The following is a description of a gene set: from publication Costello P, Nicolas R, Willoughby J, Wasylyk B, Nordheim A, Treisman R (PMID 20554967) Removal of the transcription factor SAP1a member of the Ternary Complex Factor (TCF) group of transcription factors which in conjunction with Serum Response Factor (SRF) has been shown to have a profound effect on positive selection in the thymus. When another TCF Elk1 is knocked out in mice there is no effect on positive selection unless it is on a Sap1a KO background where the phenotype is very severe. We have stimulated isolated double positive T cells (DPs) with anti-CD3 to mimic positive selection and compared basal and stimulated transcription across the four genotypes to discover the downstream targets of Sap1a involved in positive selection. Genes down-regulated in double positive thymocytes with ELK1 and ELK4 knockout: untreated versus stimulated by anti-CD3. Human Gene Set: GSE21546_UNSTIM_VS_ANTI_CD3_STIM_SAP1A_KO_AND_ELK1_KO_DP_THYMOCYTES_DN studied in species Homo sapiens, and this is the list of marker genes: PEX11G, SLC43A3, MARCHF10, FRG2EP, AKAP7, ACSL6, RNF180, PCDHA10, TLR9, OR1A2, LINC01123, TTTY13, ADRA2C, PSEN2, ASPRV1 (aspartic peptidase retroviral like 1), TSPAN16, PCDHA6, HHIP-AS1, GAS6-DT, GPATCH11, SLC5A7, H2AP, OOEP (NCBI Gene Id 648473), LINC00319, DNAJB8-AS1, LINC00269, CNNM4, CLVS2, SLC24A4, BPIFB6, ST8SIA1, CABS1, ZFP64, UBE2Q2P13, SLC8A1-AS1, SLPI, MYL2, GK2, ENSG00000267882, UBE4B, NPAS2, CAVIN2, HLA-DOA, TSEN54, PTH, WNT5B, SPAG11A, KCP, LINC02871, DKKL1, HRH3, RBM46, ZNF771, IGLV1-44, CSN2, FNDC9, CATSPERZ, PADI4, C1QA, SOCS4, SLC22A16, FGF6, CITED1, PNPLA7, LGR6, CRYAA, OR1E1, FRMPD4, ZNF507, TRMT44, CTC1, GHSR (growth hormone secretagogue receptor), TSPAN9 (NCBI Gene Id 83441), UMODL1, SFTPC, HTR1A, EQTN, KRTDAP, KRTAP11-1, LINC00921, GNG13, UGT2B28, APOA1, CYP3A43, PAMR1, S1PR1, MGC27382, TEX26, SEMA6B, CCDC172, PIK3C2B (NCBI Gene Id 5287), MTUS2-AS1 (NCBI Gene Id 731614), OR2M4, CTNNA3, OR10J1, SSTR1, DNAJB9, CRMA, PRR34, PSORS1C3, SPATA31H1, CYP19A1, ARB2A, CIMAP1C, FMO9P, FAM223A, IL2RG, CD4, CTDSP1, LINC00951, DELEC1, JPH1, SPIB, ITGB7, GOLGA8IP, SLC9A9, NTSR2, CBX7, DCAF13, CRACR2B, PRSS47P, IGSF21, CD3D, PSG1, NR2F2-AS1, LINC02487, TSSK3, LRFN2 (NCBI Gene Id 57497), DHRS13, CALCR, NANP, C1RL, SCN7A, CKMT2, CLEC4D, LSMEM2, LINC00692, PRR19, PNLIP, FRY-AS1, KDF1, RNASE3, CCL24, BMPER, ZNF174, TSPAN11 (NCBI Gene Id 441631), CCT2, ZNF296, MPPED2, JHY, SLFN11, SPMIP9, LILRA2, CFLAR-AS1, MIR1-1HG, COL11A1, IQCF1, USP29, HNRNPA0, MAFB, GRHL3, SP140, IDI2-AS1, ODC1, POLR2C, AMELX, KIR3DS1, DIPK1C, DCDC2, GKN1, HSPB3, SLC43A1, ADGRA3, CAPN12, NXPE4, SNX22, ABCC12, DAOA, NOMO3, NEURL1B, CFAP47, FCRL1, TMC1, PRL, ARIH2OS, VIPR1, SLC19A3